The following is a description of a gene set: Cyclin-dependent catalysis of the phosphorylation of an amino acid residue in a protein, usually according to the reaction: a protein + ATP = a phosphoprotein + ADP. studied in species Homo sapiens Human Gene Set: GOMF_CYCLIN_DEPENDENT_PROTEIN_KINASE_ACTIVITY, and this is the list of marker genes: CCNY, CDK19, CCNI2, CDKL4, CDK12, CCNG1, CDK13, CCNO, CDKN1B, CDKN2D, CDK8, CDKN1C, CCNB3, CDK11B, CDK7, CDK18, HEXIM2, CCNF, CDKL5, CKS1B, CDKL1, CCNQ, CDK4, CCNT1, CCNE2, CASP3, CCNL2, CDK11A, CDK3, CCND2, CDK2, HEXIM1, CDK6, KAT2B, MOK, CCNJL, CCNC, CCNK, CDK1, CCNE1, CCNA1, CNPPD1, CDKL3, CKS2, CDK20, CCNH, CDKN2A, INCA1, CDK15 (NCBI Gene Id 65061), CDK10 (NCBI Gene Id 8558), CDKL2, CDK5R2, CCNB2 (NCBI Gene Id 9133), CDK14, CDKN1A, CDK5, CDKN2B, CCNT2, CDK16, CCND1, CCND3, CCNP, CDK17, CDK9, CDK5R1, CCNB1 (NCBI Gene Id 891), CCNA2, CCNI, CDKN2C, MNAT1, CCNG2, ANKRD42 (NCBI Gene Id 732033), CCNL1, CCNJ